Given this list of marker genes Clvs2, Golga4, Ppp6c, Cd3d, Uso1, Syt9, Trappc9, Vamp4, Dctn6, Stam, Bloc1s3, Copb2, Cnih3, Cyth3, Egfr, Rab9b, Sec24a, Agpat3 (1-acylglycerol-3-phosphate O-acyltransferase 3), Necap1, Sec16b, Arf6, Dctn1, Dennd4b, Tmed3, Stx4a (NCBI Gene Id 20909), Galnt1, Rps27a, Tmed9, Kif12, Actr3 (NCBI Gene Id 74117), Ocrl, Apob, Ccz1, Ap1g2, Chmp5, Tbc1d24, Kif5b, Dennd2a, Tuba8, Rab27b, Rab32, Rab1b, Arcn1, Mon1a, Kif18b, Picalm, Tubb2b, Ap1m1, Ap2m1, Kif2c, Rab3a, Ap1b1, Scfd1, Rint1, Arfip2, Golga2, Kdelr2, Kif27, Ubap1, Rin1, Dennd5b, Sptbn4, Gdi2, Avp, M6pr, Grb2, Ubqln2, Kif9, Tor1a, Kifap3, Rab35, Tubb6, Pip5k1c, Tbc1d17, Cenpe, Ctsc, Rab36, Dync1li2, Bloc1s1, Gja3, Pafah1b3, Ins2, Gjb2, Cpd, Nbas, Rab10 (RAB10, member RAS oncogene family), Sec24d (NCBI Gene Id 69608), Fth1, Igf2r, Gjb5, Rab33a, Trappc5, Rab7, Tgfa, Arpc5, Optn, Sec31a, Copg1, Areg, Sh3gl3, Klc4, Ap2b1, Hip1r (NCBI Gene Id 29816), Copg2, Kif1b, Gabarapl2, Sec31b, Arf5, Sec24b, Ldlr, Vps54, Pacsin2, Tubb4a, Sptbn2, Eps15l1, Actr1a, Trappc8, Yipf6, Bin1, Tsc1, Trf, Epgn, Gak, Ap1s1, Cbl, Kif3c, Snf8, Itsn1, Reps1, Arfgap2, Dnm2, Snx9, Gabarap, Tacr1, Epn1, Dennd2b, Cd3g, Racgap1, Gjd3, Rab11a, Ap2s1, Rab5c, Cd55, Fcho2, Tuba1b, Ulk1, Actr10, Map1lc3b, Syt8, Rab3gap2, Plin3, Tubal3, Grk3, Kif26a, Rabgap1, Chmp2b, Dynll1, Rab39b, Fzd4, Cog8 (component of oligomeric golgi complex 8), Bet1, Alpi, Arrb2, Snap29, Kif2b, Cnih2, Snx2, Vamp8, Rabgef1, Rab21, Dtnbp1, Cops6, Ap2a1, Tbc1d15, Copb1, Dnajc6 (DnaJ heat shock protein family (Hsp40) member C6), Gcc1, Tbc1d2, Actr2, Ank1, Avpr2, Arpc2, Bicd2, Ywhae, Rab8a, Tuba4a, Trip10, Cyth1, Cltb, Stx18, Ins1, Dnase2a, Klc3, Kdelr3 (KDEL (Lys-Asp-Glu-Leu) endoplasmic reticulum protein retention receptor 3), Snap91, Dennd6a, Nsf, Dvl2, Rab1a, Rab8b, Arf1, Kif21a, Slc2a8, Gdi1, Synj2, Lman1, Ap1s3, F8, Tpd52l1, Btc, Ubb, Tsg101, Gja4 (gap junction protein, alpha 4), Usp6nl, Tbc1d10a, Cyth4, Rab3ip, Vps37d, Rab30, Tbc1d13, Tmed10, Kif20a (NCBI Gene Id 19348, kinesin family member 20A), Sbf1 (NCBI Gene Id 77980), Col7a1, Folr1, Rab38, Cog7 (component of oligomeric golgi complex 7), Rab6a, Pum1, Tuba1a, Vps37c, Rab39, Tuba1c, Lman2l, Lman1l, Mvb12a, Syt1, Tbc1d7, Gorasp1, Amph, Dennd1c (NCBI Gene Id 70785), Tubb4b, Ap3s1, Nedd8, Dennd6b, Gjd2, Ap4s1, Pla2g6, Rab4a, Pik3c2a, Vamp2, Gja1 (NCBI Gene Id 14609), Chmp2a, Arpc4, Chrm2, Rab18, Kdelr1, Gjb4, Tuba3b, here is a description of the gene set: electronically inferred by orthology from the curated human pathway Reactome Pathway: Membrane Trafficking part of: Vesicle-mediated transport species: Mus musculus This event has been computationally inferred from an event that has been demonstrated in another species.<p>The inference is based on the homology mapping from PANTHER. Briefly, reactions for which all involved PhysicalEntities (in input, output and catalyst) have a mapped orthologue/paralogue (for complexes at least 75% of components must have a mapping) are inferred to the other species.